Given this list of marker genes ADAMTS1, IRAK1, HES5, IGF1, MAP3K5 (NCBI Gene Id 4217), MEF2D, MMP2, NOX1, DDR2, MIR208A, PDGFD, EREG, RBPMS2, MIR221, AKT1, FOXJ2, JUN, XBP1, IL6, NF1, GNAI2, MIR448, EDN1, CX3CL1, MIR27A, MIR499A, IL6R, ITGA2, MIR26A1, MIR20A, PRKCA, LDLRAP1, CCL5 (C-C motif chemokine ligand 5), ELANE, MNAT1 (MNAT1 component of CDK activating kinase), S1PR1, PIK3CA, FGFR2, MAP3K7, TERT, RGCC, MYD88, ID2, DNMT1, MIR27B, TLR4, SERPINF2, MYB, FGF9 (NCBI Gene Id 2254), MIR301A, IL18, SKP2, HPGD, MFN2, THBS1, TNF, JAK2, FOXP1, PAK1, CCN4, GJA1, MMP9, HDAC1, HMOX1, PIK3R1, TGFB1, SMPD3, PDGFB, PHB1, CALCRL, NPY5R, P2RY6, HBEGF, MIR146A, BMP4, IL10, MIR214, MIR21, IL13, MIR17, NOTCH3, MIR222, BMPR1A, MDM2 (NCBI Gene Id 84825), MIR135B, AIF1, MIR130A, NR4A3, IGFBP5, PDGFRB, CDH13, STAT1 (signal transducer and activator of transcription 1), HTR1B (5-hydroxytryptamine receptor 1B), ERN1, FGF2, IRAK4, ITGB3, CYBA, here is a description of the gene set: Any process that activates or increases the rate or extent of smooth muscle cell proliferation. Human Gene Set: GOBP_POSITIVE_REGULATION_OF_SMOOTH_MUSCLE_CELL_PROLIFERATION species: Homo sapiens